The following is a description of a gene set: Frequent falls species: Homo sapiens Human Gene Set: HP_FREQUENT_FALLS, and this is the list of marker genes: PEX16, RTN2, MPZ, POLG, TAF1, RNF170, ATP6AP2, LMNA, MYPN, POLR3B, HINT1, GALC, MFN2, COQ2 (coenzyme Q2, polyprenyltransferase), PI4KA, NDUFA1, SCYL1, RETREG1, DYNC1H1, FA2H, MTPAP, BSCL2, OPA1, ASAH1, STIM1, GRIN2A, SLC12A6, NUDT2, DAB1, SLC25A4, NFU1, LRRK2, ISCU (iron-sulfur cluster assembly enzyme), NOL3, NDRG1, ATP2B3, ARSA, RRM2B, FIG4, ARHGEF2, MT-ATP6 (NCBI Gene Id 4508), CFL2, DPAGT1, FHL1, VPS13D, SH3TC2, PANK2, COL12A1, GDAP2, HADHA, VCP, GLRA1, VWA1, REEP1, GMPPB, MICU1, DNMT3B, GJB1, SPTLC1, SMG9, PRNP, MRE11, MT-TE, SLC19A3, GPHN, FKTN, RYR3, ALG2, ALG14, SLC25A42, LAMB2, PSAP, GRM1, PIK3R5, DYM, SCO2, NEB, POMT1, PDE10A, COL6A2 (NCBI Gene Id 1292), FKRP, TPM2, COL6A1, CACNA1A, DUX4, PLEC, NEFH, TPM3, CCDC78, B4GALNT1, SGCG, PMP2, ATL1, EIF4G1, DUX4L1, ADCY5, RNU12 (NCBI Gene Id 574043), GFPT1, GBA1, DNAJC13, CWF19L1, PYROXD1, CLN8, VPS35, SMCHD1, SPTAN1, SNCA, SDHA, SDHB, GIGYF2, RPL10, POLG2, KIF1C, NKX2-1, GOSR2, SPR, ACTA1, SDHAF1, SDHD, MAPT, COX20, NUP62, SGCA, LMNB2, COL6A3, COLQ, TWNK, FRG1, ADSS1, ADAR, PEX1, NUP54, CRPPA, NEFL, TTN, HADHB, CHP1, PMP22, ARG1, GDAP1, SLC25A1, SCN4A